The following is a description of a gene set: electronically inferred by orthology from the curated human pathway Reactome Pathway: Activation of the TFAP2 (AP-2) family of transcription factors species: Mus musculus part of: Transcriptional regulation by the AP-2 (TFAP2) family of transcription factors This event has been computationally inferred from an event that has been demonstrated in another species.<p>The inference is based on the homology mapping from PANTHER. Briefly, reactions for which all involved PhysicalEntities (in input, output and catalyst) have a mapped orthologue/paralogue (for complexes at least 75% of components must have a mapping) are inferred to the other species., and this is the list of marker genes: Cited4, Ep300, Cited1, Tfap2d, Cited2, Tfap2a, Tfap2e